Given this list of marker genes FMO1, FMO3, FMO4, FMO5, FMO2, here is a description of the gene set: studied in species Homo sapiens Catalysis of the reaction: N,N-dimethylaniline + NADPH + H+ + O2 = N,N-dimethylaniline N-oxide + NADP+ + H2O. Human Gene Set: GOMF_N_N_DIMETHYLANILINE_MONOOXYGENASE_ACTIVITY